Given this list of marker genes Fgf7, Sox9, Hmga2, Nfib, Srsf6, Bmp4, Wnt2, Map2k1, Foxp2, Cdc42, Fgfr2, Map2k2, here is a description of the gene set: studied in species Mus musculus The multiplication or reproduction of epithelial cells, resulting in the expansion of a cell population that contributes to the shaping of the lung. Mouse Gene Set: GOBP_EPITHELIAL_CELL_PROLIFERATION_INVOLVED_IN_LUNG_MORPHOGENESIS